The following is a description of a gene set: Crosslinking of collagen fibrils species: Mus musculus Mouse Gene Set: REACTOME_CROSSLINKING_OF_COLLAGEN_FIBRILS, and this is the list of marker genes: Loxl3, Bmp1, Col4a2, Pxdn, Col4a1, Col4a6, Pcolce, Lox, Col4a4, Col4a5, Col1a2, Loxl1, Loxl2, Loxl4, Tll1, Tll2, Col4a3, Col1a1